Given this list of marker genes PPIP5K2, STON1, VANGL1, IQCJ-SCHIP1, SMAD4, TMEM170A, RAG2, CEACAM7, MYBL1, LINC02909, FGF13, CDH6, DNPH1, ZNF224, PPP2R2A, A1CF, DAZ3, MAPK9, GNPTAB, ZDHHC21, TRIM5, RPP30 (NCBI Gene Id 283012), MEF2C, RAB1A, MAP7, FAM13A, INTS6, TMEM35A, PALM2AKAP2, PHACTR2, GFOD2, EMC6, GAB1, UBAP1, NCOA4, KITLG (NCBI Gene Id 780897), GUCY1A2, MAP1B, H1-8, CBLB, FTMT, ARHGAP28, RBM41, VDAC3, POLR3F, SLC5A8, GPR155, ZNF697, ZCCHC4, TFAP2A, EPHA7, CD8A, CCDC34, FSTL1, NAP1L3, PIK3CG, ZKSCAN8, ABCB5, TACSTD2, AAK1, CFHR5, WDR89, ACTR6, FYTTD1, GOLGA6C, RASGRP1, TINAGL1, EXOC6B, ZNF12, IFNE, PKD2L2, TRMT61B, RBM4B, COLGALT2, BIRC3, SESTD1, CD209, TENM1, ASPM, API5, CEP120 (centrosomal protein 120), KRTAP1-3, ZNF184, SUCLA2, PPP4R3A, UBXN7, USP15, GLO1, ZFC3H1, PEX3, APOB, ZEB2, IL1A, NHLRC2, CCDC39, MAPK6, CLEC3A, SPOPL, NRP2, ATXN7L1, STAU2, EPHA3, MINDY2, PDLIM5, RSBN1, LRRC8B, BHLHE22, IKZF5, C5orf24, RORA, PLEKHA8, ARF4, NFAT5 (NCBI Gene Id 10725), BMPR2, FUT9, ENDOV, PDCD6IP, ZFP36L1, R3HDM1, SEMA5A, C3orf38, ITSN1, ANKRD44, SCN7A, KATNAL1, GALNT13 (polypeptide N-acetylgalactosaminyltransferase 13), NEGR1, KCNU1, IMPACT, TMPRSS12, SPTLC2, ZBTB41, PCDH20, FHIT, ZIC1, FZD3, VCPIP1, OR7A5, ZFHX4, ANAPC7, SLC1A4, IP6K2 (inositol hexakisphosphate kinase 2), ROCK2, ARMCX4, FAM234B, APPBP2, POLR1F, CA10, CISD1, INPP4A, ATP10B (ATPase phospholipid transporting 10B (putative)), PEX26, CRY1, PPM1A, GOLGA6D, PLXDC2, MYCT1, POLH (NCBI Gene Id 5429), TJAP1, ZNF674, GPR22, RIMS3, HPSE, USP9Y, CADM2, ADH6, KPNA4, CGN, PPP1R2, MAPK8IP2, HPSE2, CTDNEP1, WAPL, DPY19L4, FGL2, OR11A1, RBSN, CSMD3, LHX8, INO80D, SPTY2D1 (SPT2 chromatin protein domain containing 1), IQGAP2, LCOR, ZNF705A, IQCJ, CYSLTR2, ZNF705D, CSRNP3, PEX2, FBN2, VGLL3, DOCK9, BNC2, WIPF2, HNRNPR, USP25, ZNF585B, PSMB4, ITGB1BP2, TENT2, LPP, DDX21, DUSP6, ZNF705EP, ITGB8, MRPL19, PRPF38A, PTPRK, FMC1-LUC7L2, LIMA1, PPP2R5A, AKAP11, PCDH10, DEPTOR, MVB12B, ZFP69, CCNC, FAM107B, ATP11C, RLIG1, TRAPPC3, BCAT1, NDUFC1, RIC8B, STXBP6, CDH18, TAS2R14, LCP2, MKLN1, RIPOR1 (NCBI Gene Id 79567), REEP5, MROH1 (NCBI Gene Id 84500), LRRC39, ZNF451, LUC7L2, PPM1B, CNGA1, OSBPL8, RAB39B, SETD9, DR1, SORCS1, DSC1, CLDN1, MAT1A, RNF139, here is a description of the gene set: from publication Chen Y, Wang X (PMID 31504780) Genes predicted to be targets of miRBase v22 microRNA hsa-miR-10522-5p in miRDB v6.0 with MirTarget v4 prediction scores > 80 (high confidence targets). species: Homo sapiens Human Gene Set: MIR10522_5P